Given this list of marker genes IQCE, PLA2G5, HR, CT62, RUSC1, STK40, ALCAM, here is a description of the gene set: from publication Chen Y, Wang X (PMID 31504780) Genes predicted to be targets of miRBase v22 microRNA hsa-miR-483-5p in miRDB v6.0 with MirTarget v4 prediction scores > 80 (high confidence targets). species: Homo sapiens Human Gene Set: MIR483_5P